The following is a description of a gene set: species: Mus musculus Any process that modulates the frequency, rate or extent of the chemical reactions and pathways involving any hormone. Mouse Gene Set: GOBP_REGULATION_OF_HORMONE_METABOLIC_PROCESS, and this is the list of marker genes: Stub1, Nfkb1, Igf1, Cyp17a1, Rdh16f2, Akr1c18, Bmp6, Atp1a1, Slco1c1, Duoxa2, Dab2, H6pd, Pax8, Gh, Bmp2, Gnb3, Tcf7l2, Ppargc1a, Kcnma1, Gata3 (GATA binding protein 3), Wnt4, Hif1a, Gfi1, Bmp5, Cacna1a, Pde8b (phosphodiesterase 8B), Nr3c1, Rdh19, Rdh16, Fshr, Nr5a2, Egr1, Ffar3, Arnt, Clcn2, Dkk3, Prmt3, Igf2, Dgkq, Igf1r, Por, Lhcgr, Stc2, Rest, Rdh10, Gal, Hpn, Rdh1, Ctns, Duoxa1, Myt1, Rdh9, Cyp27b1, Zmpste24